The following is a description of a gene set: species: Homo sapiens from publication Jeffrey KL, Brummer T, Rolph MS, Liu SM, Callejas NA, Grumont RJ, Gillieron C, Mackay F, Grey S, Camps M, Rommel C, Gerondakis SD, Mackay CR (PMID 16474395) In the present study we used Affymetrix oligonucleotide microarrays to produce gene transcription profiles for the major leukocyte types in humans. This comprehensive dataset enabled us to not only establish which genes were expressed in each leukocyte type, but also which genes were expressed in each subset after activation. The used of a comprehensive dataset of gene profiles from all the major human leukocyte subsets enabled a novel and powerful means for identification of genes associated with single leukocyte subsets, or different immune paradigms. Human Gene Set: GSE3982_MAC_VS_CENT_MEMORY_CD4_TCELL_UP Genes up-regulated in comparison of macrophages versus central memory CD4 T cells., and this is the list of marker genes: RAB5IF, KIF1B, QPRT, PMFBP1, UBL4A, GPI, PNP, CXCL5, SCG5, ME1 (malic enzyme 1), BACH1, PTRH2, FAM162A, PCOLCE2, IVD, CD83, CENPN, EIF4A1, ATP6AP1, RCBTB2, CLASP2, CSF1, GINS2, CPM, SLC47A1, PAM, ACOT7, SOX4, NOP10, SSR3, PRDX3, H2AC4, EPHX1 (NCBI Gene Id 2052), APLP2, COQ2, TPK1, HCAR3, ZDHHC3, FOSL1, CYP51A1, FUCA1, MRPL40, MATK (megakaryocyte-associated tyrosine kinase), BLTP3B, SWAP70, LAIR1, ATP5MC1, TRPV2, ACO1, ADAP2, PLD3, TK1, INHBA, VDR, TNFRSF12A, SEM1, STX3, ELOB, GABARAP, EBP, TUBB, RMDN1, TACSTD2, CD14, CEBPA, RRM2, HSPB1, CCDC47, TEX2, MS4A6A, SLC38A2, ADGRE3, ADA2, PLA2G15 (phospholipase A2 group XV), ACSL3, PSMB5, COX8A, CDA, WIPI1, ACSL1, RNH1 (ribonuclease/angiogenin inhibitor 1), GLRX3, LYN, CPVL, HLA-DPB1, MT1X, TPGS2, ENSA, KCNJ1, ERP44, FCGR2B, TFF3, LNPEP, NDUFV2, TXNRD1, SIDT2, TMEM14B, MBD4, NSDHL, DNAJB6, QPCT, TSC22D1, LSM3, CDK4, PSMD12, FBXO38, RPN1, CKS2, PXDC1, ORC1, CLEC2B, CD52, RGS20, SH3BGRL3, KIF11, PSMA2, MTHFD2, ESR1, ITGA3, TIMM8B, RTN1, AREL1, RHBDF2, MTCH2, CYFIP1, SIRPA, TMEM184C, ENOSF1, GASK1B, TUBA1C, ARHGEF40, PRKAR2B, CPT2, TRAPPC4, MRPL15, TREM1, CTSS, TIMM17A, SLC7A8, NACC2, CLIC1, CEP170, ACP2, AP4S1, IDH1 (NCBI Gene Id 3417), ATP5MF, ECHS1 (enoyl-CoA hydratase, short chain 1), SQOR (sulfide quinone oxidoreductase), PLEK2 (pleckstrin 2, NCBI Gene Id 26499), TMEM53, BLOC1S1, LILRB1, VAC14, CTSH, PLAU, VCP (NCBI Gene Id 94731), SLC43A3, CENPU, PROC, VDAC1, PCLAF, LASP1, C3AR1, MIR22HG, NENF, CTSC, EOGT, SEL1L, CHKA, ITGAX, FXYD6, TM6SF1, GNA12, PDXK, MYL9, CHUK, STXBP1 (NCBI Gene Id 6812), ERCC1, NTAN1, CYBRD1, MPC2, KEAP1, HSD17B4, SLC39A1, ANKRD6, PIK3CB, AGGF1, SAP30, PICALM, MYO5A, AHCYL1, CES1, RER1, RENBP, AMD1, PPT1, GSTT1, AZI2, GALC, REXO5